The following is a description of a gene set: Catalysis of the hydrolysis of any non-peptide carbon-nitrogen bond in a linear amide. studied in species Mus musculus Mouse Gene Set: GOMF_HYDROLASE_ACTIVITY_ACTING_ON_CARBON_NITROGEN_BUT_NOT_PEPTIDE_BONDS_IN_LINEAR_AMIDES, and this is the list of marker genes: Vnn1, Hdac3, Klk1b26, Hdac5, Fhit, Aspa, Nit1, Ndst1, Pm20d1, Hdac11, Park7, Nadsyn1, Cad, Hdac6, Gls, Hint3, Pglyrp2, Asah2, Hdac7, Hdac1, Sirt2, Acer3, Upb1, Aspg, Hdac2, Ntaq1, Acer1, Sirt1, Klk1b27, Tgm2, Faah, Hdac10, Sirt4, Ntan1, Ndst2, Afmid, Nit2 (nitrilase family, member 2), Klk1b24, Hdac8, Amdhd2, Aga, Gls2, Pm20d2, Cat, Naalad2, Sirt5, Klk1b1, Klk1b4, Acy3, Ngly1, Hint1, Pglyrp3, Klk1b21, Acer2, Klk1b9 (NCBI Gene Id 13648), Klk1b11, Acr, Vnn3, Pdf, Btd, Klk1b8, Hdac4, Asah1, Ndst3, Acy1 (aminoacylase 1), Pigl, Hint2, Klk1b16, Klk1b3, Klk1b22, Asrgl1, Naaa, Pglyrp4, Pglyrp1, Ndst4, Klk1b5, Klk1 (kallikrein 1), Hdac9